Given this list of marker genes IGF2R, MYO1E, TGFBR1, SZT2, CRB1, KDR, C12orf57, MMUT, BAK1, RC3H2, JAK2, GATA3, PLEKHA1, BCL11B, ATRX, BCL2, KDM5B, SELENOP, HMGN1, DNMT3A, ZFY, CCDC47, NPPC (natriuretic peptide C), LARGE1 (LARGE xylosyl- and glucuronyltransferase 1), TAL2, FZD5, KMT2A, PSEN1, MYL2 (NCBI Gene Id 4633), VEGFA, KAT8, SLC18A2, MORC3, BMP4, TIPARP, ETNK2, GIGYF2, ACO1, GABRG2, SCUBE1, NR4A2, BCL2L11, CELA1, PPP1R13L, ALX4, ATF5 (activating transcription factor 5), SCN9A, AGO2, RAB3A, PLAGL2, CSRNP1, INPPL1, BAX, CHST11, MECP2, TP73, TBCE, ASH1L, FGFR2, BPNT2, ASL, ABL1, HELT, FOXP2, APOB, DSCAM, LHX1, EVA1A, SOD2, HEG1, SMAD2 (NCBI Gene Id 654050), KLF4, MTOR, SEMA3C, DNMT3L, SERP1, ACADM, ARID5B, ACVR2B, NKX2-3, VPS54, EMX1, PRDM1, CYP1A2, SGPL1, LLGL2, ATM, SLC4A10, STK36, IREB2, ATN1, ERCC1, ALDH5A1, KCNJ1, NDN, ERCC2, ITPR1, here is a description of the gene set: species: Homo sapiens Human Gene Set: GOBP_POST_EMBRYONIC_DEVELOPMENT The process whose specific outcome is the progression of the organism over time, from the completion of embryonic development to the mature structure. See embryonic development.